Given this list of marker genes IL1RAP, IL1RAPL2, PTPRS, PPFIA3, SLITRK1, SLITRK4, SLITRK5, PPFIBP1, LRRC4B, SLITRK6, PPFIA4, SLITRK2, NTRK3, PPFIA2, PPFIA1, PPFIBP2, PTPRD, PTPRF, SLITRK3, IL1RAPL1, here is a description of the gene set: part of: Protein-protein interactions at synapses Reactome Pathway: Receptor-type tyrosine-protein phosphatases Like neurexins, Receptor-like protein tyrosine phosphatases (RPTPs) make trans-synaptic adhesion complexes with multiple postsynaptic binding partners to regulate synapse organization. The type IIa RPTPs include three members, Receptor-type tyrosine-protein phosphatase F (PTPRF) sometimes referred to as leukocyte common antigen-related (LAR), Receptor-type tyrosine-protein phosphatase sigma (PTPRS) and Receptor-type tyrosine-protein phosphatase delta (PTPRD). These proteins contain typical cell adhesion immunoglobulin-like (Ig) and fibronectin III (FNIII) domains, suggesting the involvement of RPTPs in cell-cell and cell-matrix interactions. To date, six different types of postsynaptic organizers for type-IIa RPTPs have been reported: interleukin-1 receptor accessory protein (IL1RAP, IL-1RAcP), IL-1RAcP-like-1 (IL1RAPL1), Neurotrophin receptor tyrosine kinase 3 (NTRK3, TrkC), Leucine-rich repeat-containing protein 4B (LRRC4B, Netrin-G ligand-3, NGL-3), the Slit- and Trk-like (Slitrk) family proteins and the liprins. studied in species Homo sapiens